Given this list of marker genes Tgfbr3, Acvr2b, Smad2, Fst (NCBI Gene Id 99160), Inha, Acvr2a, Inhba, Smad3 (SMAD family member 3), Fstl3, Mapk1, Inhbb, Mapk3, Smad4, Acvr1b, Acvr1c, here is a description of the gene set: Signaling by Activin Mouse Gene Set: REACTOME_SIGNALING_BY_ACTIVIN studied in species Mus musculus